Given this list of marker genes SFMBT1, ZNFX1, FANCB, GCC1, DYNLT2B, GALNT1, THAP1, TMEM68, PTPRO, MUC13, COX19, NAT10, SRP72, COMTD1, GCLM, TMEM43, PTCD2, CTSH, RAB34, SS18L2, NSDHL, ELL2, IL22RA2, CEACAM21, CNNM4, SGK1, C18orf54, TMEM26, CTBP2, HYCC1, CLDN12, IFT70B, GNG12, ZNF516, CNR2, ATG4A, STOM, YIPF5, HOOK3, RBM19, MTRES1, PLEKHF1, TTC39C, SLPI, PLIN2, COX16, TFR2, GPI, MBD1, IER3IP1, RACGAP1, GOLIM4, SLC25A24, CHST13, COQ10B, SMAP1, RBMS1, MIS18BP1, ARHGAP19, IL11RA, TESK2, LCN2, CTDSPL, KNSTRN, GET1, IFTAP, PAQR3, TSC22D2, ITGA2B, HEATR5A, SPAG5, COX6A1, FMC1, ATP6V0B, ALG14, DEPDC1, TWF1, TRIP4, STXBP6, MUL1, GAR1, LHFPL2, TXNDC11, SNX7, COX10, NBEAL1, RAP2A, CHI3L1, NUP58, GLA, TRABD, CCDC127, WSB2, CELA1 (NCBI Gene Id 1990), GDAP2, AK4, SEPTIN10, C1QBP, L2HGDH, C1QTNF12, DACH2, TECPR2, ACSL1, C11orf24, HDAC8, KRI1, ABCA9, CHEK2, SLC48A1, SKA3, RNF214, GRIA3, FCER1G, DGKG, CCDC18, SCIN, C1orf122, MYO1F, CIAO3 (cytosolic iron-sulfur assembly component 3), SEMA4A, NANS, SEPHS2, SUSD1, NCKAP1, CENPW, SH3D19, KCTD9 (NCBI Gene Id 54793), VCAM1, PCYT1A, TRAPPC3, LRR1, HROB, AP5B1, SNORD89, CSF2RB, GADD45B, XDH, GORASP2, GDPGP1, CEP76, DARS2, MOB1B, DNAJC12, ELANE, DFFA, NAT9, ERGIC3, TIFAB, TMEM241, LRP4 (LDL receptor related protein 4), HTATIP2, ERBB3, LTB4R, SETD6, TCTN3, MASTL, SLC19A2, ZNF227, CDC45, DENND2D (DENN domain containing 2D), FKBP1B, IPMK, TOP3B (NCBI Gene Id 8940), ATP6V0C, TMEM50B, GCA, HDLBP, GK5, CYP39A1, NEIL3, NEAT1, RAD54B, MND1, ABCC4, OAF, CEP350 (centrosomal protein 350), INTS10, TBC1D24, TTC21A, PLCB1, ICA1, DSP, TYW5, GPALPP1, GRB14 (NCBI Gene Id 2888), RBKS (NCBI Gene Id 64080), AFG2B, CRY2, MAP3K20, PTGS1, CYLD, REEP1, MCPH1, MED8 (NCBI Gene Id 115853), SC5D, INTS3, NXPE4, RUNDC1, TUBB2A, SLC16A7, here is a description of the gene set: Primary HBE cells were stimulated with IL-22 and IL-17, and gene expression was studied using an Affymetrix platform microarray, in order to investigate which genes may be upregulated or downregulated in response to these cytokines. Of particular interest was the host defense genes such as antimicrobial peptides, which have been shown to be upregulated by IL-22 and IL-17 in skin keratinocytes. from publication Aujla SJ, Chan YR, Zheng M, Fei M, Askew DJ, Pociask DA, Reinhart TA, McAllister F, Edeal J, Gaus K, Husain S, Kreindler JL, Dubin PJ, Pilewski JM, Myerburg MM, Mason CA, Iwakura Y, Kolls JK (PMID 18264110) Genes down-regulated in primary bronchial epithelial cells stimulated with: IL22 versus IL17A. Human Gene Set: GSE10240_IL22_VS_IL17_STIM_PRIMARY_BRONCHIAL_EPITHELIAL_CELLS_DN studied in species Homo sapiens